Given this list of marker genes RNA5S11, BTF3P9, MAP10, RN7SL668P (RNA, 7SL, cytoplasmic 668, pseudogene), ENSG00000244137, FAM133FP, MIR1182 (NCBI Gene Id 100302132), RN7SKP276, RNA5SP162, ENSG00000212144, ENSG00000227496, ENAH, RN7SL837P, CCSAP, COA6, OBSCN-AS1, RNU2-70P, COA6-AS1, NVL, TRIM17, SLC35F3-AS1, ACTA1, LNCATV, LINC01736, SEPTIN14P17 (NCBI Gene Id 106480344), NTPCR, CNIH4, ABCB10, LINC01744, CNIH3, ENSG00000237101, MIR4666A, SDE2, LIN9, ENSG00000286071, RNF187, ENSG00000282564, H2BC27P, LINC01641, NUP133-DT, ENSG00000285177, ACBD3, MIR4671, TAF5L, LINC00184, KIAA1191P3, BTNL10P, DUSP5P1, MRPL55, RN7SKP49, CIAO2AP2 (CIAO2A pseudogene 2), WNT9A, IBA57-DT, LINC01132, ENSG00000303653, PCNX2, MTND4P10, ITPKB-IT1, C1orf198, RNA5S15, LEFTY3P, FAM89A, MTCO3P46 (NCBI Gene Id 107075293), AKR1B1P1, B3GALNT2, MIR4742, ENSG00000225656, NUCKS1P1, SPRTN, ISCA1P2, DNAJB6P6, RNA5S12, RNA5S4, RNA5S8, LINC02961, RNA5S13, SEPTIN7P13, GTF2IP20, RPL23AP15, DISC1, RAB4A, MIR1537, GJC2, EXOC8, LINC01703, MTND5P19, RNU6-1008P, TSNAX, RN7SKP165, LDHAP2, MTND3P8, TOMM20, MIR320B2, GPR137B, DNAH14, CNIH3-AS1 (CNIH3 antisense RNA 1), COG2, LINC01348, C1orf35, RPS27P5, MIR4753, CDKN2AIPNLP1, RNA5SP19, MAP3K21, RPL23AP23, CICP5, LINC02809, TTC13, YBX1P9, DISC1-IT1, RNA5S1, ARV1, TBCE (tubulin folding cofactor E), SNAP47, WNT3A, RAB4A-AS1, GGPS1, H3-4, LINC00582, MIR5008, IRF2BP2, H2AC25, RNU4-21P, EPHX1 (epoxide hydrolase 1), URB2 (URB2 ribosome biogenesis homolog), RNA5SP78, RNU4-77P, MIR3620, NID1, RHOU, MIR4427, AGT, LINC01745, CAPN9, RPS3AP7, H2BC26, RNA5S3, ENSG00000233461, RNU5A-5P, RNA5S10, SNORA14B, TUBB8P10, GNG4, PGBD5, JMJD4, C1orf131, H3-3A, RNA5S17, SRP9, MIXL1, SIPA1L2, MTCYBP14, HMGB1P26, PYCR2, HMGN2P19, PARP1, WDR26, LINC01737, PRSS38, LINC03108, RNA5S2, LINC02971, ARID4B, ENSG00000287259, RNA5S16 (RNA, 5S ribosomal 16), TUBB8P9, RPS21P1, RNA5SP80, SNORA72, ITPKB, RNY4P16, IBA57, LYST, ACBD3-AS1, ENSG00000286774, ENSG00000298651, RNA5S5, LBR, LEFTY1, RNU6-180P, TMEM63A, ERO1B, ENSG00000232628, RNU6-1304P, RNU1-74P, TRIM11, ENSG00000228044, CNIH3-AS2, ITPKB-AS1, RNA5SP18, NUP133, LINC02765, RBM34, PSEN2, EDARADD, RNA5SP77, RNA5S7, MIR6741, TARBP1, RN7SL299P, MIR6742, TRIM67, TSNAX-DISC1, UBA5P1, CDC42BPA, CICP26, MTND6P14, COQ8A, ENSG00000233332, KCNK1, TRIM67-AS1, H3-3A-DT, GALNT2, STUM, SNAP47-AS1, SNRPD2P2, LINC02813, GUK1, RNU6-1319P, ZNF678, SLC35F3, NDUFA3P3, ZNF847P, TMEM78, RNA5S14, ARF1, ACO2P2, OBSCN, FBXO28, LINC01354, RPS7P3, RNU6-968P, RAC1P7, LINC02814, EGLN1, RNA5S6, FTH1P2, ENSG00000286389 (novel transcript), MTND4LP21, LINC01682, RNA5SP79, RNA5S9, RNU6-1211P, LINC02768 (long intergenic non-protein coding RNA 2768), GNPAT, LEFTY2, DEGS1, here is a description of the gene set: Human Gene Set: chr1q42 studied in species Homo sapiens